Given this list of marker genes DLEC1, KCNJ5, KCNJ2, RAB3GAP2, HEPHL1, WWOX, ALG3, RNF6, SALL1, PIGH, TGFBR2, FRA10AC1, CKAP2L, here is a description of the gene set: Human Gene Set: HP_CLINODACTYLY_OF_THE_5TH_TOE Clinodactyly of the 5th toe species: Homo sapiens Bending or curvature of a fifth toe in the tibial direction (i.e., towards the big toe).